Given this list of marker genes RFC5, DSCC1, RFC2, CHTF18, CHTF8, RFC1, RFC3, RAD17, RFC4, here is a description of the gene set: Human Gene Set: GOMF_DNA_CLAMP_LOADER_ACTIVITY Facilitating the opening of the ring structure of the PCNA complex, or any of the related sliding clamp complexes, and their closing around the DNA duplex, driven by ATP hydrolysis. species: Homo sapiens